The following is a description of a gene set: Vesicle-mediated transport species: Mus musculus Mouse Gene Set: REACTOME_VESICLE_MEDIATED_TRANSPORT, and this is the list of marker genes: Tmed7, Snx18, Masp1, Tubb1, Kif4, Yipf6, Tgoln1 (trans-golgi network protein), Igkv17-121, Aak1, Cd4, Apoa1, Kif13b, Ighv8-8, Stx5a, Rab1a, Sec23a, Rabepk, Ubb, Cog8 (component of oligomeric golgi complex 8), Dctn1, Pafah1b2, Dennd1b, Rab11a, Dab2, Kdelr1 (KDEL (Lys-Asp-Glu-Leu) endoplasmic reticulum protein retention receptor 1), Pum1 (NCBI Gene Id 80912), Igkv11-125, Trappc12, Apol9b, Vti1a, Rps27a, Cog3, Agtr1a, Cd36 (NCBI Gene Id 12491), Ppp6r3, Chmp5, Ighv5-9, Cyth2, Igkv1-88, Uso1, Stx6, Grk3, Lrp2, Hbb-bt, Hba-a1, Cd3d, Kifap3, Gria1, Chmp6, Sec24a, Tpd52l1, Rab35, Kif27, Rhobtb3, Agfg1, Golga1, Copz2, Cops2, Ighv5-12, Scoc, Slc18a3, Tbc1d14, Akt1, Tsc2, Igkv1-132, Igkv1-131, Kif21b, Slc2a8, Src, Apol7c, Kif3c, Apol7e, Clta, Egfr (epidermal growth factor receptor), Arf4, Ap2a2, Cd59b, Ighv12-3, Rab11b, Vps53, Rab21, Gabarap, Ulk1, Stab2, Igkv2-137, Sptb, Ighv5-9-1, Epn1, Sptbn2, Apol10a, Fnbp1, Madd, Snx5, Actr2 (actin related protein 2), Pafah1b1, Sptan1, Trip10, Sparc, Trappc5, Dctn5, Snx9, Cftr, Tmed3, Jchain (immunoglobulin joining chain), Apol7b, Ap2s1, Cnih3, Lman2, Cbl, Chm, Snap91, Trappc11, Apoe, Fcho2, Galnt2, Mia3, Ighv8-11, Tuba3b, Rab33b (NCBI Gene Id 211346), Dnm2, Tuba8, Sec13, Col7a1, Vamp3, Ldlr, Ap3b1, Chmp7 (charged multivesicular body protein 7), Ftl2-ps, Dctn3, Arf3, Vps37d, Tubal3, Tmed2, Bet1, Igkv1-135, Agpat3, Golga2, Avpr2, Synj2, Gjb2, Vamp2, Dynll1, Hgs, Arcn1, Grk2, Ap3s1, Kif1c, Akt3, Map1lc3b, Sh3gl3, Tbc1d16, Tmed9, Ighv6-7, Use1, Necap1, Chmp4b, Gps1, Dennd3, Mon1a, Alb, Tpd52, Vps51, Igkv16-104, Gjc2, D130043K22Rik, Rab9, Scgb3a2, Gapvd1, Fth1, Gorasp1, Tbc1d2, Rint1, Ighv8-12, Ankrd28, Bloc1s3, Scfd1, Ap1s3, Gak, Gjb4, Igf2r, Rab4a, Ykt6, Igll1, Gabarapl2, Stab1, Sec24c, Kif2c, Mon1b, Kif28, Klc3, Tubb4a, Arpc1a, Clvs2, Rin1, Cd55, Grb2, Cog5, Fzd4, Nedd8, Syt2, Vps36, Ighv3-1, Kif26a, Pla2g6, Rab7b, Hip1r, Igkv1-117, Picalm, Trappc2, Tfg, Igkv1-99, Ywhae, Ighv6-6, Hspa8 (NCBI Gene Id 69197), Bloc1s1 (biogenesis of lysosomal organelles complex-1, subunit 1), Ap1g2, Rab3gap1, Msr1, Ighv13-2 (NCBI Gene Id 629842, immunoglobulin heavy variable 13-2), Vps37c, Ubqln2, Rinl, Sptbn5, Eps15l1, Arrb2, Uba52rt, Ctsz, Cops7b, Colec11, Kifc1, Ppp6c, Surf4, Rab14, Kifc5b, Sh3gl1, Dctn6, Ap1g1, Sec22a, Igkv1-122, Gosr1, Ap2a1, Tacr1, Sec24d, Alpi, Ap1b1, Dennd2a, Igkv1-110, Cops8, Scarb1, Napa, Ocrl, Rab30, Dnm3 (NCBI Gene Id 98663), Sh3d19, Dync1li1 (dynein cytoplasmic 1 light intermediate chain 1), Trappc1, Sptbn4, Copa, Snap23, Apol9a, Chmp2a, Cyth3, Dync1h1, Folr1, Racgap1, Calr, Lman2l, Klc2 (NCBI Gene Id 16594), Sec31a, Akt2, Ccz1, Sec24b, Arf5, Marco (NCBI Gene Id 98310), Ighv7-3, Zw10, Rab10, Apol11b, Tbc1d15, Vps28, Kif15, Kif20a, Sec22b, Tgfa, Kif18a, Ighv3-4, Ap1s2, Adrb2, Itsn2, Tbc1d13, Ighv5-2, Dennd1a, Ap2b1, Cyth1, Lrp1, Kif12, Vamp4, Kdelr3, Syt11, Ighv5-6, Cenpe, Trappc6b, Ambp, Cope, Sbf2, Dennd4c, Dync1li2, Dennd2c, Synj1, Mcfd2, Ighv8-6, Sytl1, Bnip1, Syt8 (synaptotagmin VIII, NCBI Gene Id 55925), Hip1, Cnih1, Chrm2, Copg2, Kifc2, Vps52, Rab39b, Rab8a, Cops4, Chmp4c, Ap4e1 (adaptor-related protein complex AP-4, epsilon 1), Kif1a, Pip5k1c, Tor1b, Rabgef1, Trf (NCBI Gene Id 22041), Gcc1, Capza2, Trappc13, Il7r, Rab18, Rab5c, Ighv5-16, Pla2g4a, Ank1, Sec31b, Iglc1, Tubb6, Tmem115, Gosr2, Chml, Rab7, Rab39, Tbc1d25, Ighv8-9, Sys1, Cops7a, Rab36, Tubb4b, Sh3gl2, Dennd1c, Gjc1, Epgn, Necap2 (NECAP endocytosis associated 2, NCBI Gene Id 99985), Kif18b, Dennd4b, Rab32 (NCBI Gene Id 67844), Stx4a, Arfgap3, Gcc2, Kif20b, Arl1, Amph, Clint1, Ubc, Tuba3a, Kif3b, Actr3, Cyth4, Ighv8-4, Apol8, Copb2, Ap1s1 (adaptor protein complex AP-1, sigma 1), Tbc1d17 (TBC1 domain family, member 17), Kif23, Vta1, Kif5a, Ap4s1, Sec23ip, Kif3a (NCBI Gene Id 192824), Ubqln1, Kif22, Sar1b, Dynll2, Gjd3, Copg1 (coatomer protein complex, subunit gamma 1), Serpina1c, Pafah1b3, Dnm1, Gns, Tuba1c (NCBI Gene Id 22146), Preb, Ighv8-13, Rab5b, Napb (NCBI Gene Id 56276), Rab27a, Kif2a, Igkv8-21, Itsn1 (NCBI Gene Id 16443), Tuba1b, Ap2m1, Avp, Sbf1, Apol10b, Golga4, Dnajc6, Copb1, Cltb, Igkv20-101-2, Dennd5a, Klc4, Dennd2d, Chmp3, Ighv8-5, Cd163, Dctn4, Ighv5-17, Chmp2b, Gjb3, Tsg101, Gjd2, Bloc1s4, Spta1, Trappc9, Gdi2, Bet1l, Kif2b, Trappc10, Gja10, Vps25, Kif9, Cops5, Dnase2a, Gja3, Bicd2, Syt1, Igkv15-103, Btc, Rab13, Rab31, Apob, Lman1 (lectin, mannose-binding, 1), Acbd3, Trappc4, Arf6, Gjd4, Tubb2b, Bin1, Cd3g, Dennd5b, Ap1m2, Igkv18-36, Ighv3-5, Igkv1-133, Ighv3-8, Rab6a, Scarb2, Tbc1d10b, Arpc3, Rab12, Bicd1 (NCBI Gene Id 319962), Cltc (NCBI Gene Id 97762), Rab3gap2, Rab33a, Myo6, Cpd, Stx17, Tbc1d10a, Ighv3-6, Dync1i2, Rab43, Reps2, Kif26b, Hps4, Mia2, Tbc1d24, Arf1, Reps1, Sh3kbp1, Ap4m1, Cog4, Gdi1, Ap1m1, Plin3, Capzb, Igkv1-35, Tjp1, Pacsin2, Rab3a, Gjb6, Vps4b, Tfrc, Cops3, Gja5 (NCBI Gene Id 70659), Lman1l, Gjb1, Trappc2l, Stam, Ighv7-4, Trappc3, Copz1, Ins1, Nbas, Serpina1b, Cog1, Tbc1d10c, Ighv5-12-4, Fcho1, Syt9 (NCBI Gene Id 60510), Cog6, Tbc1d20, Als2cl, Mvb12b, Cog7, Wnt5a, Vps37b, Txndc5, Actr10, Ighv16-1, Optn, Stam2, Rab3il1, Ighv7-2, Tubb2a, F8, Dennd6b, Rab9b, Dync1i1, Dtnbp1, Ighv6-4, Arpc5, Arfgap1, Golgb1, Alppl2, Vamp8, Kif11, Akp3, Gja8, Rab8b, Rin3, Trappc8, Ric1, Ldlrap1 (low density lipoprotein receptor adaptor protein 1), Tubb3, Epn2, Vps54, Als2, Gja4, Arfgap2, Kif19a, Kdelr2, Vps4a, Ighv5-4, Actg1, Stx18, Sort1, Hpx, Pacsin3 (protein kinase C and casein kinase substrate in neurons 3), Dennd6a, Vps37a, Dctn2, Areg, Uba52, Ctsc, Arfrp1, Pik3c2a, Hsp90b1, Sec16b, Ston2, Trip11, Tuba4a, Fnbp1l, Tmed10 (transmembrane p24 trafficking protein 10), Pacsin1, Rab6b, Apol7a, Bloc1s6, Snapin, Gbf1, Rabgap1, Mvb12a, Tmf1, Ighv8-2, Galnt1, Kif6, Clvs1, Igkv2-109, Arpc2, Rab1b, Klc1, Hp (haptoglobin), Dennd4a, Nsf, Cog2, Gja1, Kif5b, Hbegf, Arfip2, Ap4b1, Ighv6-5, Stx16, Csnk1d, Rab5a, Ighv3-3, Tor1a, Eps15, Gjb5, Rin2, Ighv5-15, Tbc1d7, Rab3ip, Kif21a, M6pr, App, Kif1b, Iglc2, Napg, Cnih2, Ppp6r1, Trappc6a, Igha, Hps1, Sec22c, Dvl2, Capza3, Cops6, Arpc4, Ston1, Tbc1d8b, Dennd2b, Actr1a, Tuba1a, Ankrd27, Snap29, Ighv6-3, Rgp1, F5, Egf, Sec16a, Actb (NCBI Gene Id 11476), Sptbn1, Usp6nl, Arrb1, Apol11a, Tsc1, Vps45, Igkv2-112, Snf8, Rab27b, Ubap1, Hbb-bs, Ereg, Kif16b, Rab38, Snx2